Given this list of marker genes Actr3, Ephb2, Ephb4, Itsn1, Efnb2, Arpc5, Arpc2, Ephb1, Arpc4, Grin1, Grin2b, Fyn, Rasa1, Ephb6 (NCBI Gene Id 13848), Actr2 (actin related protein 2), Ptk2, Hras, Efnb3, Efnb1, Cdc42, Ephb3, Yes1, here is a description of the gene set: electronically inferred by orthology from the curated human pathway part of: EPH-Ephrin signaling This event has been computationally inferred from an event that has been demonstrated in another species.<p>The inference is based on the homology mapping from PANTHER. Briefly, reactions for which all involved PhysicalEntities (in input, output and catalyst) have a mapped orthologue/paralogue (for complexes at least 75% of components must have a mapping) are inferred to the other species. Reactome Pathway: EPHB-mediated forward signaling species: Mus musculus